The following is a description of a gene set: Genes down-regulated in activated CD4 T cells expressing: wildtype versus mutant form of FOXP3. Investigation of the role of FOXP3 in CD4+ T effector cells. FOXP3 is transiently upregulated in T effector cells under activation. This temporary expression in Teff cells is insufficient to suppress expression of reported targets of FOXP3 repressor activity. The role of FOXP3 in T effector cells remains unclear. We used microarray analysis to detail the differentially expressed genes between FOXP3 wild type and 2T>C(mut) clones and identified classes of up-regulated or down-regulated genes based upon FOXP3 expression. from publication McMurchy AN, Gillies J, Gizzi MC, Riba M, Garcia-Manteiga JM, Cittaro D, Lazarevic D, Di Nunzio S, Piras IS, Bulfone A, Roncarolo MG, Stupka E, Bacchetta R, Levings MK (PMID 23169781) species: Homo sapiens Human Gene Set: GSE41087_WT_VS_FOXP3_MUT_ANTI_CD3_CD28_STIM_CD4_TCELL_DN, and this is the list of marker genes: PGAP3, FCER1G, MGST3, SETD3, HEBP2, PTTG1, UBA6, FGF13 (NCBI Gene Id 730528), GPD1L, DRAM1, ATP6V1D, IFI35, IGF1, NISCH, NDUFS6, ADRB2, ALDH18A1, ELL, SPAG5, NARS2, WDR12, RALB, TFPT, SREBF1, IL10RB, NIPSNAP1, TFDP1 (transcription factor Dp-1), RAB3IL1, IPO13, ALDH1A1, RAD51AP1, CDK4, BST1, ERG28, NDUFB3, KDM4D, CLTA, POLE2, VAT1, LONP1, ANKRD46 (NCBI Gene Id 157567), HPF1, CCNB2, GUSB, VWA5A, CPNE3, ACAA1, TK1, OPRL1, PLAU, ANO10, PTPA, SUCLG2, COLEC12, SLC38A6, RHOBTB1, GPSM2, GGCT, RENBP, LINC00342, BLVRB, TMEM33, ATP5MC3, EPB41L2, MKI67, SELPLG, KIF20A, SDHC, PRDX1, GLCE, CD59, DHCR24, STAB1, CDC45, MGST2, PEBP1, UAP1L1, TPK1, FANCG, APOO, BAG5, NRP1, NCAPG, GYG1, MS4A6A (membrane spanning 4-domains A6A), CACNA2D3, LAP3, ACO1, ATP5MF, HPCAL1, DAG1, TBC1D31 (NCBI Gene Id 93594), FRMD4A, HTT, EIPR1, RAD54B, P4HTM, POP5, MSR1, COMMD9, MTHFD1, BABAM2, DUSP7, CTSV, FARP1, STMN1, BUB1B, ATP5F1B, TPGS2, CUEDC2, MTX2, ARHGAP4, ACACA, SKIC3 (NCBI Gene Id 9652), ACP5, HK2, QPRT, STX3, VTI1B, PSMB5, WDR7, QDPR, TMEM160, EPAS1 (endothelial PAS domain protein 1), CLEC3B, AKR1A1, RPN2 (ribophorin II), MRPS33, HEMK1, TMC6, SNCA, AKR7A3 (NCBI Gene Id 22977), TUBB2A, EIF4G3, PYCARD, AIFM1 (NCBI Gene Id 9131), SORD (NCBI Gene Id 6652), HMOX2, TTK, HGH1, GALK2, COX5B, SDC3, APOBEC3B, ENOSF1, PAAF1, MOSPD3, ADISSP, CD14, E2F8, GM2A, PDIA5, RIDA, FCGR1BP, NDC80, CCDC51, UQCRQ, MDH2, TMPO, TRIM32, LIG1, BLOC1S1, FANCI, GOT1, TP53TG1, SNRPF, ACP2, FERRY3, SNX3, HGSNAT, CDKN3, ATP5F1C, HADH, BHLHE40, TIMP2, P4HA1, PINK1, GRAMD4, TBC1D16, BLNK, GIMAP5, ARMC9 (armadillo repeat containing 9), FOCAD, APEH, MACIR, PREPL, RNASE2, PUDP, GNG12, F13A1, TSPAN4, EXTL2, FOXK2, APH1B, DSN1, HIBCH, FOLR2, UQCRH, TNFSF12, RTL8C